The following is a description of a gene set: species: Homo sapiens Any process that modulates the rate, frequency, or extent of prostate gland branching, the process in which the branching structure of the prostate gland is generated and organized. A branch is a division or offshoot from a main stem. Human Gene Set: GOBP_REGULATION_OF_BRANCHING_INVOLVED_IN_PROSTATE_GLAND_MORPHOGENESIS, and this is the list of marker genes: HOXD13, BMP7, BMP4, SFRP1, ESR1